The following is a description of a gene set: Human Gene Set: GOBP_EPITHELIAL_CELL_FATE_COMMITMENT species: Homo sapiens The process in which the developmental fate of a cell becomes restricted such that it will develop into an epithelial cell., and this is the list of marker genes: NRP1, SOSTDC1, PDPN, NOTCH1, ACVR1, HOXA13, NEUROD1, RBPJ, PROX1, RARA, DLL1, ARX, NKX2-2, NR2F2, SPDEF